The following is a description of a gene set: Human Gene Set: GOBP_AMINO_ACID_BIOSYNTHETIC_PROCESS The chemical reactions and pathways resulting in the formation of amino acids, organic acids containing one or more amino substituents. species: Homo sapiens, and this is the list of marker genes: PLOD2, SEPHS2, SRR, GOT1L1, SERINC5, BHMT, OTC, CAD, PYCR1, SLC1A3 (solute carrier family 1 member 3), GAD1, PCBD1, GLS2, GLUD2, APIP, ASL, ADI1, CLN3, GGT1, ABAT, BHMT2, AGXT, ENOPH1, PARK7, ASS1, GLUD1, PLOD3, ATP2B4, CARNS1, GLS, PYCR3, MTHFD2L, MTR, GOT2, DPYD, PSPH, PAH, MRI1, ENSG00000274276, BCAT2, MTRR (NCBI Gene Id 4552), SEPHS1 (NCBI Gene Id 88214), MTHFD1, LGSN, CBS, SHMT2, GOT1, PSAT1, ALDH18A1, HAO1, ALDH1A1, AGXT2, PHGDH, PYCR2, BCAT1, SERINC3, GAD2, CTH, UPB1, ASNSD1, SHMT1, NOXRED1, GLUL, SLC38A1, CPS1, NAGS, OAT, ASNS